The following is a description of a gene set: studied in species Homo sapiens Genes predicted to be targets of miRBase v22 microRNA hsa-miR-6857-5p in miRDB v6.0 with MirTarget v4 prediction scores > 80 (high confidence targets). Human Gene Set: MIR6857_5P from publication Chen Y, Wang X (PMID 31504780), and this is the list of marker genes: ABCB7, CLCF1, SHC1, HECTD3, MAP3K12, TMEM169, PKP2, GRIA1, BMP7, CREB3L2, SLC39A13, PSMD2, HNRNPD, APH1A, TP53AIP1, ADGRA3, ATP2B4, TULP1, SLC38A1, ZNF585B, TRAM1, C3orf36, PIK3CA, SGCB, GOLT1A, BTN3A1, ELK1, CSNK1A1, SPATA31C2, AGPS, TRIM67, MICU1, TOM1, ARID4A, UAP1L1, ENPP1, PGRMC2, ZMAT2, BCAM, CRYBG3, NECTIN1, LMO7, ATOSA, LRRC38, NRL, ACVR2A, ST7, LARGE1, CLIP3, WDFY3, PLEKHS1, TAP2, HSD17B11, MAP10, MYO15A, DCLRE1C, RTKN2, FOXM1, ARGFX, TADA3 (transcriptional adaptor 3), HTR3E, IFNLR1, ELAVL3, FGFR1, TAC3, DENND1B, WARS2, ISM1, SLC25A23, RPS6KA1, DEPDC1, BRWD1, PARPBP, IGF2, HOXA3, RASGEF1B, ILDR2, GRIN2B, SRXN1